The following is a description of a gene set: studied in species Mus musculus from publication Chen Y, Wang X (PMID 31504780) Mouse Gene Set: MIR_187_5P Genes predicted to be targets of miRBase v22 microRNA mmu_miR_187_5p in miRDB v6.0 with MirTarget v4 prediction scores > 80 (high confidence targets)., and this is the list of marker genes: Tmem250, Dnaja2 (NCBI Gene Id 76342), Fam193a, Tmem30b, Tfap2a (transcription factor AP-2, alpha), Hook1, Irgq, Ppp1r7, Hdx, Shpk, Ro60, Gm5142, Rnf13, Slc6a8, Slitrk5, Thsd7b, Trpc4, Morf4l2, Stbd1, Xk, 1600014C10Rik, Eif4b, Insig1, Thrb, Sult1a1, Sall4, Rph3a, Il36rn, Atp7a, Mbtd1, Fgl2, Stac, Mapk8, Pakap, Nrarp, Igf2bp2, Mcemp1, Nadk2, Fbxl20, Zeb2, Pcgf3, Rras2, Txndc16, Spryd4, Zfp422, Usp27x, Zfp212 (NCBI Gene Id 232784), Uri1, Rgs4, Cpa4, Fut2, Clock, Dhcr24, Pkdcc, Baiap3, Mapk13, Six4, Cnot1 (CCR4-NOT transcription complex, subunit 1), Ifi213, Cbfb, Srp68